Given this list of marker genes Eif2ak3, Crebrf, Eif2s3x (NCBI Gene Id 26905), here is a description of the gene set: Reactome Pathway: Unfolded Protein Response (UPR) electronically inferred by orthology from the curated human pathway part of: Cellular responses to stress This event has been computationally inferred from an event that has been demonstrated in another species.<p>The inference is based on the homology mapping from PANTHER. Briefly, reactions for which all involved PhysicalEntities (in input, output and catalyst) have a mapped orthologue/paralogue (for complexes at least 75% of components must have a mapping) are inferred to the other species. species: Mus musculus